Given this list of marker genes Tcf7, Tnf, Gata4, Sall1, Tgfb2, Shox2, Sox11, Hnf1b, Rarb, Gli2, Rbpms2, Pcsk5, Id2, Pdgfra, Stra6, Fgf9, Tcf7l2, Gli3, Tcf21, Pkdcc, Fgfr2, Ada, Aldh1a2, Foxf1, Fgf10, Ovol2, Foxf2, Vps52, Shh, Nipbl, Hlx, Ihh (Indian hedgehog), Pitx2, Myb, Six2, Rarres2, here is a description of the gene set: The process whose specific outcome is the progression of the gut over time, from its formation to the mature structure during embryonic development. The gut is the region of the digestive tract extending from the beginning of the intestines to the anus. species: Mus musculus Mouse Gene Set: GOBP_EMBRYONIC_DIGESTIVE_TRACT_DEVELOPMENT